The following is a description of a gene set: Mouse Gene Set: MIR_7004_3P Genes predicted to be targets of miRBase v22 microRNA mmu_miR_7004_3p in miRDB v6.0 with MirTarget v4 prediction scores > 80 (high confidence targets). studied in species Mus musculus from publication Chen Y, Wang X (PMID 31504780), and this is the list of marker genes: Ldc1, Tub, Saysd1, Suds3, Slc1a1, Snx10, Syngr3, Col10a1, Psg16, Ptprg, Mapkbp1, Cldn4, Acvr1b, Slc5a1, Tpt1, Fam131b, Usp9x, Lrrc8e (NCBI Gene Id 97482), Npas3 (neuronal PAS domain protein 3), Fbxl17, Ino80d (NCBI Gene Id 329170), Slc30a9 (NCBI Gene Id 76440), Snph, Glt1d1, Ccng1, Spsb1, Gjc3, Opcml, Acox1, Mageh1, 1110059E24Rik, Wnt8b, Ppp1r3f, Zfp456, Aoc2 (NCBI Gene Id 237940), Grk1, Mas1 (NCBI Gene Id 17171)